Given this list of marker genes SCN4A, KCNJ18, CPOX, GABRA3, PPOX, HMBS, KCNE3, ALAD, CACNA1S, here is a description of the gene set: Inability to move the muscles of respiration. Respiratory paralysis Human Gene Set: HP_RESPIRATORY_PARALYSIS species: Homo sapiens